The following is a description of a gene set: Binding to oxysterol, an oxidized form of cholesterol. studied in species Homo sapiens Human Gene Set: GOMF_OXYSTEROL_BINDING, and this is the list of marker genes: INSIG1, OSBPL5, EPHX1, VDAC2, TMEM97, GAS1, TMEM199, VDAC1, RORA, OSBP, GPR141, CAV1, SMO, INSIG2, GPR183, RORC